Given this list of marker genes Maoa (monoamine oxidase A), Cacna2d1, Slamf1, Palld, Tmpo, Zfp65, Arhgap6, Zfp704, Flrt3, Il7r (interleukin 7 receptor), Slc24a2, Cdcp1, Fam168b, Tmf1, Pip4k2a, Ano3, Rsad1, Rora, Vegfc, Ttr (transthyretin), Hdgfl3, Slc6a8, Trpm3, Tet2 (tet methylcytosine dioxygenase 2), Plp1, Rgmb, Il33, F13a1, Nav1, Pla2g2d, Glul, Nipbl, Tub, Fam120a, Rpp14, Adgre4, Pramel3c, Cbln2, Ppargc1a, Tfcp2l1, Ubxn2a, Tasor, Ndrg4, Spcs1, Thap11 (NCBI Gene Id 76841, THAP domain containing 11), Celsr1, Parp16, Xkr6, Kcnd2, Ro60, Heg1, Zyg11b, Zmym5 (NCBI Gene Id 219105), Tnrc6a, Rbbp7, Kdm4c, Ube2g2, Kcnj3, Srebf1, Pramel3b, Cfl2, Hsf2bp, Lrch2, Armc8, Grk4, Brinp1, Xiap, Eif4g2, Ddx5, Agfg1, Purb, Lrrtm3, Pdlim5, Zfp623, Nfatc2, Gcnt1, Tmem255a (transmembrane protein 255A), Igsf3, Tent5a, Gbe1, Slc17a6, Cyp2j5, Foxb1, Igf1, Scarf1, Pik3ca, Commd2, Nox1, Pik3r3, Grik2, 1810010H24Rik, Fam228a, Lrrc2, Cdc14b, Edn1, Fgf13, Arhgap36, Arpc5, Tmem127, Ceacam1, Gabpa, Pim1, Ar, Slitrk4, Draxin, Spred2, Psmd12, Slc7a7, Corin, Sel1l, C130050O18Rik, Foxp1, Rin2, Ube2r2, Bcl11a, Ghr, Sprr2a3, Il23r, Cdh2, Pan2, Stxbp5, Gria2, Arl13b, Dnmt3a, Npat, Dhx33, Thsd4, Wwp1, Qki, Ccdc127, Dcdc2a, Phf20, Ptprj, Col3a1, 1700029H14Rik, Cnot7 (NCBI Gene Id 18983), Garem1, Col12a1, Fscn3 (fascin actin-bundling protein 3), Onecut2, Polr3e, Rbms3, Dlk1, Nkd2, Kcnh8, Phf6, Cers4 (ceramide synthase 4), Dennd1b, Fbxo8, Ednrb, Tbx3, Ajap1, Elovl6, Hivep3, Nrxn1, Mosmo, Hoxa2, Tob2, Etl4, Ciita (class II transactivator), here is a description of the gene set: Genes predicted to be targets of miRBase v22 microRNA mmu_miR_19b_2_5p in miRDB v6.0 with MirTarget v4 prediction scores > 80 (high confidence targets). Mouse Gene Set: MIR_19B_2_5P studied in species Mus musculus from publication Chen Y, Wang X (PMID 31504780)